The following is a description of a gene set: Cellular immunodeficiency species: Homo sapiens Human Gene Set: HP_CELLULAR_IMMUNODEFICIENCY An immunodeficiency characterized by defective cell-mediated immunity or humoral immunity., and this is the list of marker genes: SDHC, WRAP53, ATM, HELLS, FOXN1, CTC1, NPM1, RTEL1, TYMS, EP300, ZBTB24, PIK3CA, USF3, SDHB, DNMT3B, KLLN, NOP10, NHP2, PARN, SDHD, AK2, SMARCAL1, TINF2, DKC1, CREBBP, TERC, TBCE, UHRF1, EXTL3, ACP5, EPG5, USB1, AKT1, PTEN, SEC23B, FRAS1, RMRP, TERT, CDCA7 (cell division cycle associated 7)